Given this list of marker genes KCNK2, KCNK13, KCNK17, KCNK4, KCNK9, KCNK16, KCNK18, KCNK3, KCNK6, KCNK1, KCNK10, KCNK7, here is a description of the gene set: part of: Potassium Channels studied in species Homo sapiens Tandem pore domain K+ channels (K2p) produce leak K+ current which stabilizes negative membrane potential and counter balances depolarization. These channels are regulated by voltage independent mechanisms such as membrane stretch, pH, temperature. Tandem pore domain K+ channels have been classified into six subfamilies; tandem pore domains in weak rectifying K+ channel (TWIK), TWIK-related K+ channel (TREK), TWIK-related acid-sensitive K+ channel (TASK), TWIK-related alkaline pH-activated K+ channel (TALK), tandem pore domain halothane-inhibted K+ channel (THIK), TWIK-releated spinal cord K+ channel). Reactome Pathway: Tandem pore domain potassium channels